Given this list of marker genes NUDT19, FITM2, ELOVL6, ELOVL1, ELOVL5, SLC27A2, DGAT1, HACD2, FAR1, ACSL4, FAR2, NUDT7, ELOVL7 (NCBI Gene Id 79993), ACSL6, ACSL1, ACAT1, HACD1, ELOVL4, GCDH, DGAT2, HTD2, CBR4, NUDT8, TECR, ELOVL2, ACSF3, THEM5, ACSL3, ACSBG2, HSD17B12, ABCD1, FASN, PPT2, ACSM2A, ACSBG1, ELOVL3, ACSL5, ACOT7, PPT1, HSD17B4, ACACA, here is a description of the gene set: The chemical reactions and pathways involving a fatty-acyl-CoA, any derivative of coenzyme A in which the sulfhydryl group is in thiolester linkage with a fatty-acyl group. Human Gene Set: GOBP_FATTY_ACYL_COA_METABOLIC_PROCESS species: Homo sapiens